The following is a description of a gene set: Human Gene Set: HP_ABNORMAL_URINARY_COLOR species: Homo sapiens Abnormal urinary color An abnormal color of the urine, that is, the color of the urine appears different from the usual straw-yellow color., and this is the list of marker genes: ALAD, PYGM, MPV17, ABCC2, HMBS, MT-CO3, CLTRN, HGD, IFT56, STAT4, IRAK1, ATP11C, CPOX, LPIN1, SPP1, TSC1, UROD, OBSCN, CPT2, AKR1D1, MT-CO1, UROS, SAT1, SLC6A19, DMD, BLVRA, TSC2, GATA1